The following is a description of a gene set: Monocyte-derived dendritic cells (DC) and macrophages (MΦ) generated in vitro from the same individual blood donors were exposed to five different pathogens, and gene expression profiles were assessed by microarray analysis. Responses to Mycobacterium tuberculosis and to phylogenetically distinct protozoan (Leishmania major, L. donovani, Toxoplasma gondii) and helminth (Brugia malayi) parasites were examined, each of which produces chronic infections in humans yet vary considerably in the nature of the immune responses they trigger. from publication Chaussabel D, Semnani RT, McDowell MA, Sacks D, Sher A, Nutman TB (PMID 12663451) Human Gene Set: GSE360_L_MAJOR_VS_B_MALAYI_LOW_DOSE_MAC_UP species: Homo sapiens Genes up-regulated in comparison of macrophages exposed to L. major versus macrophages exposed to 5 worms/well B. malayi., and this is the list of marker genes: ZBTB17, ZPR1, GABPA, RASSF7, SPRR1A, SPON1, BBS4, FBLN1, EFNB2 (NCBI Gene Id 1948), MYOZ3, DIO2 (NCBI Gene Id 1734), TRIM10, DPP6 (dipeptidyl peptidase like 6), PHKG1, NUP58, SLC16A3, HTATIP2, SLC12A4, CPA3, MT1E (metallothionein 1E), GNA13, ZSWIM8, RNF126, PCDH8, CCDC69, RABEP1, TRIAP1, NTF3, CAP2, MISP, TDG, DNASE1, REL (NCBI Gene Id 5966), NALF1, CSTB, BMP6, TANK, COIL (NCBI Gene Id 96825), SGCE, GALNT18, IL12B, RFPL3S, PLK4, TNP2, RPS17, EFNA5, PAX9, MYH10, LEP, RNFT2, PTPRK, SLC20A1, TCF15, TNFSF12, GCDH, NQO1, NFKB1, DLGAP1, MLN, PDE1A, STAT4, COL17A1, CCR7, IDUA, CSN3, LAMTOR5, MAPK8IP1, RYR1, ACTN1, MTMR9, LZTR1, CYP1B1, RHOBTB3 (Rho related BTB domain containing 3), CCL20, CHGB (chromogranin B), DNAJB4, ZNF674, YIPF4, ZBTB25, INSIG2, BRINP1, MAPK1IP1L, LCP2, ZNF44, ACAP1, KCNK1 (potassium two pore domain channel subfamily K member 1), SRPK1, ATP5PD, CALCA (calcitonin related polypeptide alpha), MUC2, SP100 (NCBI Gene Id 6672), MINPP1, CCN2, IL4, PFDN4, FCHO1, NECTIN2, SSTR5, ERCC5, SYCP1, PPP1CB, MLLT10, TH (NCBI Gene Id 7054), RAD54L, CHP1, FGF3, RSRP1, CLDN3, UPP1, POLR2D, TFIP11, G0S2, PTPN9, RIMBP2, ITGAX, NAV3, SLC11A2, RAN, KTN1, FCGR3A, HNRNPF (NCBI Gene Id 3185), ZNF33B, SERPINH1, KIF20B, NAE1, RSL1D1, DRC3, NAA80, WSCD1 (NCBI Gene Id 23302), SYN3, AHSG, MARCO, POLR3C, ZNF157, HLX, CLK3, SELENOW, BET1, FKBP4, PFKP, GAPVD1, TIMM17B, PARP2, NR1H2, NCDN, HSP90AA1, PKM, PXN, DYNC1I1, DKK3, YWHAZ, MAFK, CHST3, SIT1, SUPT4H1, NRDC, LAMB3, P2RX5, GRB14, COL7A1, TOP1, SPEG, SOD3, GABRB2, MMRN1, MTCP1, BDNF, MSMB, PIP5K1B, CDK17 (cyclin dependent kinase 17), CFHR2, SLC7A7, VRK1, FBXO7, PPP3CB, CFTR, ATOSB, APEX2, ICOS, AFM, PPP1R10, PTS, NFKBIA, ARL1, GSK3B, PLAGL2, SYNPO, COL13A1, PPBPP2, SDC2, CD44, UBE3A, RABL3, BAAT, GPI, REN, GART (NCBI Gene Id 2618)